The following is a description of a gene set: Any process that modulates the rate, frequency, or extent of the orderly movement of an endothelial cell into the extracellular matrix to form an endothelium. Human Gene Set: GOBP_REGULATION_OF_ENDOTHELIAL_CELL_MIGRATION studied in species Homo sapiens, and this is the list of marker genes: RHOJ, RIN2, MIR143, MIR199A1, PTK2B (protein tyrosine kinase 2 beta), ADAMTS9, MIR101-1, ADAM17, STAT5A, TMEM201, TNF, GDF2, MIR132 (NCBI Gene Id 406921), ROCK2 (NCBI Gene Id 9475), AGT, PTGS2, FGF1, NRP2, BCAS3, ATP5F1B, MIR29C, THBS1, MMRN2, MIR129-1, MIR499A, SMOC2, SYNJ2BP, MIR150, HMOX1, FUT1, PIK3C2A, KDR, MIR329-1, MIR200B, MIR196A1, AGTR2, MIRLET7F1, MIR149, TBXA2R, BSG, P2RX4, PIK3CG, ETS1, VEGFA, MIR210, MIR221, ROBO4, MIR497, MIR505, MIR495, NOS3, MIR424, CIB1, ANXA3, PPARG, MIR26A1, SRPX2, FLT4, MEF2C, GADD45A, FGF16, MIR29A, VEGFC, SASH1, EGF, MIR20A, PLG, TGFBR3, PDCD6, TEK (NCBI Gene Id 7437), NRP1, MIR27A, PRCP, RHOB, PDGFB, MIR135B, ATOH8, LGMN, MIR640, WNT7A, AMOT, SVBP, MIR19B1, ANGPT1, ITGB1BP1, KLF4, FGF2, GATA3, ADGRB1, CRIPTO, ANGPT4, MIR503, MIR342, PRKD2, EMP2, HMGB1, ABL1, CXCL13, LCN2, PROX1, MIR483, MIRLET7B, DLL4, FGFBP1, VASH1, MIR494, SPARC, RGCC, MIRLET7A1, SP100, MIR137, PRKCA, CEACAM1, MIR10B, MIR2355, MIR361, NOTCH1, MIR206, MIR21, GAB1 (GRB2 associated binding protein 1), GRN, TGFB1, CD40, CCBE1, EDN1, GPLD1, FOXC2, ANGPT2, RRAS, EPHA2 (NCBI Gene Id 1969), SEMA5A, MIR152, MIR1908, DNAJA4, MIR15B, PDPK1, MIR31, PTK2, MIR320A, SH3BP1, CALR, CARD10, AAMP, MIR15A, RAC1 (Rac family small GTPase 1), MAP2K3, MIR487B, MIR10A, HDAC7, NF1, GFUS, SCARB1, MIR27B, GLUL, PIK3CD, PLPP3, MIR492, GATA2, MIR410, HDAC5, TMSB4X, MIR92A1, MIR296, ACVRL1, MIR23A, HRG, MAPK14, KRIT1, MAP2K5 (NCBI Gene Id 5607), ZC3H12A, MIR126, PLK2, ANXA1, BMPER, AKT1, MECP2, STC1, ITGB3, JCAD, SPRED1, HIF1A (hypoxia inducible factor 1 subunit alpha), MIR133B (microRNA 133b), GPI, FGF18, FGF4, SIRT1, MIR204, FGFR1, MIR885, PRKD1, PDCD10, SEMA4A, MIR30A, BMP10, AKT3, BCAR1, MIR200C, ADGRA2, JUP, ATP5F1A, EFNA1, MET, SERPINF1 (serpin family F member 1), SLIT2, MIR205 (microRNA 205), MIR939 (microRNA 939), MIR212, EMC10, RHOA, GREM1, APOH, HDAC9, WNT5A, NFE2L2, MIR16-1, PTN, DCN, MIR146A, NR2E1, HSPB1, MIR24-1, NUS1, FOXP1, PLCG1, CSNK2B, ZNF580, STARD13, PATZ1, MIR193A, NR2F2, SP1, MMRN1, PIK3CB, PTPRM, APOE, MIR200A, DAB2IP, MIR22, MEOX2, ATP2B4